The following is a description of a gene set: The candidate tumor suppressor BAP1 is a deubiquitinating enzyme (DUB) involved in the regulation of cell proliferation, although the molecular mechanisms governing its function remain poorly defined. BAP1 was recently shown to interact with and deubiquitinate the transcriptional regulator host cell factor 1 (HCF-1). Here we show that BAP1 assembles multiprotein complexes containing numerous transcription factors and cofactors, including HCF-1 and the transcription factor Yin Yang 1 (YY1). Through its coiled-coil motif, BAP1 directly interacts with the zinc fingers of YY1. Moreover, HCF-1 interacts with the middle region of YY1 encompassing the glycine-lysine-rich domain and is essential for the formation of a ternary complex with YY1 and BAP1 in vivo. BAP1 activates transcription in an enzymatic-activity-dependent manner and regulates the expression of a variety of genes involved in numerous cellular processes. We further show that BAP1 and HCF-1 are recruited by YY1 to the promoter of the cox7c gene, which encodes a mitochondrial protein used here as a model of BAP1-activated gene expression. Our findings (i) establish a direct link between BAP1 and the transcriptional control of genes regulating cell growth and proliferation and (ii) shed light on a novel mechanism of transcription regulation involving ubiquitin signaling. from publication Yu H, Mashtalir N, Daou S, Hammond-Martel I, Ross J, Sui G, Hart GW, Rauscher FJ 3rd, Drobetsky E, Milot E, Shi Y, Affar el B (PMID 20805357) Genes deregulated in U2OS cells (osteosarcoma) upon knockdown of BAP1 by RNAi. Human Gene Set: YU_BAP1_TARGETS studied in species Homo sapiens, and this is the list of marker genes: UXS1, CDC25A, PDGFRA, BRIP1, CDK1, COX7C, BIRC5, CYB5R1, RBL1, NPL (N-acetylneuraminate pyruvate lyase), ELOVL6, CDC5L, CCND2, E2F5, CA2, CCNE2, USP1 (ubiquitin specific peptidase 1), BAP1, CDC45, RAD51B, TNFRSF10B, BRCA1, GMNN, BCL2A1, CDC6, RFC3, CHEK1, TADA3, SKP2